The following is a description of a gene set: CD25+ regulatory T cells develop in the thymus (nTregs), but may also be generated in the periphery upon stimulation of naive CD4 T cells under appropriate conditions (iTregs). The mechanisms that regulate the generation of peripheral iTregs are largely unknown. We used microarrays to gain insights into the molecular program of extrathymic Treg development. from publication Prots I, Skapenko A, Lipsky PE, Schulze-Koops H (PMID 21347372) Human Gene Set: GSE24634_NAIVE_CD4_TCELL_VS_DAY10_IL4_CONV_TREG_UP Genes up-regulated in comparison of naive T cells at day 0 versus CD25+ regulatory T cell (Treg) treated with IL4 at day 10. studied in species Homo sapiens, and this is the list of marker genes: TNNT3, RPS28, WDR74, TSPAN6, DGKZ, BIN1, OVGP1, COL11A2, UXT (ubiquitously expressed prefoldin like chaperone), ROS1, AVPI1, ADTRP, SMAD7, ZFP2, TFCP2L1, SNHG3, DCXR, IRF6, ALS2CL, PTGER1, GALNT11, MAN1C1 (NCBI Gene Id 57134), HP1BP3, RNF144A, PHAF1, CCDC59, RPH3A, SHH, GZMM, CACNA1H, RASGRP2, EPHA1, SLC3A1, GRHL2, PLA2G1B, TSPAN1, HGF, NAP1L3, RPL10P17, CPA4, LAS1L, LTBP2, ZNF669 (NCBI Gene Id 79862), ZNF331, PRICKLE3, ZNF510, SC5D, EFHD1, NOL12, IRF3, UPK2, EGFR, PDE4B, PEPD, FASTK, PTHLH (parathyroid hormone like hormone), TGFA, CDC37L1, PNRC1, GCNT3, FHIT, LYRM9, C19orf53, APBA2, LEPROTL1 (leptin receptor overlapping transcript like 1), WNT7A, CAMK2B, ATP1A2, CDC25C, CDHR5, PLEKHB1 (pleckstrin homology domain containing B1), GPR153, TFAP2C, ZNF516, SNHG17, KBTBD11, CDK3, SCARB2, AMH, LENEP, NAA15 (N-alpha-acetyltransferase 15, NatA auxiliary subunit), H2AC14, RPS10P5, CCNP, RPL27A, INCENP, ALLC, NPY6R, DPYSL4, TTPA, PDK1, PLAC8, MSL2, MRPL49, AK5, TRIM10 (NCBI Gene Id 95309), H2BC8, RHOBTB3, RPL11, NELL1, ADGRL2, KRT18, ZNF329, RPL38, TPST1, SUSD4, ALOXE3 (NCBI Gene Id 64048), NRP2, PFDN5 (prefoldin subunit 5), FCGRT, SPINK4, OMP, BCAS4 (breast carcinoma amplified sequence 4), PRAMEF10, OR2C1, PLXNB1, GRB7, SGF29, SEC14L2, PRRX1, GALNT12, TBL1Y, PRPH, DCN, ULK2, TOE1, JADE1, KANK1, OTUD3, RPL35A, ACSM3, RNFT2, WNT10B, MCTP1, RPL19, RPL27, ITGA6, DCAF4, RPS12, TSSK2, OSER1 (NCBI Gene Id 51526), CXADR, TTC27, SLC16A6, RASA3, NBPF10, PIK3IP1, IL6ST (interleukin 6 cytokine family signal transducer), MAP2K6, ACVRL1, LAMC3, RAPGEFL1, JOSD1, CFAP410, OPRPN, ARHGAP32, MRM3, STARD5, INTS15, AGXT, ABCF3, LRIT1, LIG1, ZFAND3, TESMIN, PDP1, NCAM1, FAU, GTPBP6, RPL35, PYY, EEF1G (eukaryotic translation elongation factor 1 gamma), KLF13 (NCBI Gene Id 51621), DGKD, TSPYL2, TOB1, ACVR1B, GPRASP1, MEPCE, UBIAD1, SELL, RPS15A, ADAM22, CD248, CCNT1, SPDEF, RIPK2, ATG14, XKR8, KANSL2, PDCD4-AS1, DXO, BNC1, PLA2G2E, ASPH, TGFBR2, CSH1, ICOSLG